Given this list of marker genes Sigirr, Il1r1, Il1rn, Zbp1, Il1r2, Otud4, Vrk2, Il6, here is a description of the gene set: Any process that modulates the frequency, rate or extent of interleukin-1-mediated signaling pathway. studied in species Mus musculus Mouse Gene Set: GOBP_REGULATION_OF_INTERLEUKIN_1_MEDIATED_SIGNALING_PATHWAY